The following is a description of a gene set: HDR through Single Strand Annealing (SSA) studied in species Homo sapiens Human Gene Set: REACTOME_HDR_THROUGH_SINGLE_STRAND_ANNEALING_SSA, and this is the list of marker genes: HUS1, ERCC1, RPA1, MRE11, NBN, RFC4, TOP3A, BRCA1, ATM, RMI2, RAD51, ATRIP, ERCC4, RAD1, RAD17, BARD1, RAD9A, RFC3, RHNO1, DNA2, EXO1, ABL1 (ABL proto-oncogene 1, non-receptor tyrosine kinase, NCBI Gene Id 25), RAD50, RPA2, BRIP1, RPA3, BLM, TOPBP1, WRN, RAD52, ATR, RFC5, RMI1, RAD9B, RFC2, RBBP8 (NCBI Gene Id 5932), KAT5